The following is a description of a gene set: The process in which a miRNA is targeted for degradation by a non-coding RNA or mRNA. The binding of an RNA to a target miRNA within a RISC complex results in either ubiquitin-mediated degradation of AGO protein or the displacement of the 3' end of the miRNA, exposing it to nucleases. species: Homo sapiens Human Gene Set: GOBP_TARGET_DIRECTED_MIRNA_DEGRADATION, and this is the list of marker genes: OIP5-AS1, ELOC, TENT2, ELOB, ZSWIM8